The following is a description of a gene set: Human Gene Set: GOBP_CHROMOSOME_LOCALIZATION Any process in which a chromosome is transported to, or maintained in, a specific location. species: Homo sapiens, and this is the list of marker genes: CHMP6, SIRT2, NSL1, NUMA1, CDT1, SKA1, CHMP2B, VPS4B, CHMP7, BUB3 (BUB3 mitotic checkpoint protein), TERF1, CDCA5, INCENP, ECT2, EML4, TTL, BOD1, RRS1, DLGAP5, MAD1L1, MEIOC, SPAG5, LMNA, SGO1 (shugoshin 1), TEX14, NEK2, IFFO1, MIS12, RMDN1, RACGAP1, RAB24, CENPQ, KIF2B, CDC42, BECN1, TTK, CDC23, APC, KNL1, KATNB1, ZWINT, HNRNPU, KIF14, FAM83D, SKA3, ZNF207, SPICE1, CHMP1A, MLH1, KASH5, EML3, CHMP1B, ACTR2, NDC80, NDEL1, CCNB1, CHMP4B, MAPRE1, PDCD6IP, BIRC5, SIRT1, CHMP4A, RAB11A, TERB2, KNTC1, VPS4A, UBE2B, KAT2B, CUL3, KIF18A, DCTN2, NUDC, ATM, KIF22 (kinesin family member 22), DYNC1H1, KAT5, FMN2, SPDYA, CHAMP1, ANKRD53, SKA2, SPC24, PINX1, SUN1, SPO11, AURKC, CENPF, KNSTRN, CHMP4C, ABRAXAS1, NUF2, ACTR3, DSN1, TRAPPC12, MAJIN, ABRAXAS2, CEP55, PMF1, PSRC1, TERB1, CENPC, NUP98, ZW10, PIBF1, KIF2C, MAP1S, SPDL1, KIFC1, AURKB, RB1, SPC25, CCDC66, CHMP5, NUP62, RCC2, CDCA8 (NCBI Gene Id 55143), SEH1L, CENPE, ZWILCH, GEM, NDE1, KPNB1, CHMP2A, SEPTIN1, CHMP3, CHMP4BP1, CDK1